Given this list of marker genes ANK2, OS9, ZRANB1, WDR81, UFD1, TP53BP1, CGAS, CBX2, UBQLN3, PSMD4, LYN, RNF31, TAB2, UBQLN4, ZMYND8, SHARPIN, PTPN6, IKBKE, SPIN4, MINDY2, TRIM24, CHD1L, BRD4, SOCS2, ING1, XRCC1, ING3, MLLT3, EP300, OTUD7A, PHF8, VCP, MINDY1, MPHOSPH8 (M-phase phosphoprotein 8), MORC3, CDYL, TAF1L, SPIN2B, TNIP3, CBX3, UBXN1, FAM156A, SPIN3, ZRANB3 (NCBI Gene Id 84083), ASCC2, TOPBP1, SOCS7, MACROH2A1, PRPF8, AFG2B, ATRIP, SETD5, ATRX, CDYL2, BRD9, RRP8, AGAP3, PLCG2, APLF, SPRTN, UIMC1, PARP10, L3MBTL2, BPTF, TOM1, FAM156B, ZFAND2B, MORC4, ZCWPW2, SPIN2A, L3MBTL1, PSME4, ABRAXAS1, UBAC1, NBN, YWHAG, AGL, ING2, PHF20L1, EED, PHIP, HTATSF1, UBQLN1, RAD18, MLLT1, MPND, ATAD2B, BAG6, RNF168, PHF13, RNF169, OPTN, RAD23B, PARP2, ING4 (NCBI Gene Id 51147), DNAJB2, UBQLNL, HDAC6, OTUD7B, L3MBTL3, BRD2, PHF1, BRD3, CXXC1 (NCBI Gene Id 54105), KMT2E, CBX1, BRCC3, DZIP3 (NCBI Gene Id 9666, DAZ interacting zinc finger protein 3), BRD7, VAV1, IKBKG, YEATS2, ZFAND6, MBTD1, UHRF1, NPLOC4, SQSTM1, DPPA3, SPIN1, EPS15, UBL7, MTF2, BABAM2, ZBTB1, ZMYND11, TNFAIP3, BRDT, UBQLN2, CBX6 (chromobox 6), ZCWPW1, FAAP20, RAD23A, CBX8, CBX5, TAB3, PHF19, ABRAXAS2, TNIP2, SGF29, ING5, here is a description of the gene set: Binding to a protein upon post-translation modification of the target protein. species: Homo sapiens Human Gene Set: GOMF_MODIFICATION_DEPENDENT_PROTEIN_BINDING